Given this list of marker genes BSG (NCBI Gene Id 682), SLC16A7, SLC16A1 (solute carrier family 16 member 1), EMB, SLC16A8, SLC16A3, here is a description of the gene set: Reactome Pathway: Proton-coupled monocarboxylate transport studied in species Homo sapiens part of: SLC-mediated transport of organic anions The SLC16A gene family encode proton-linked monocarboxylate transporters (MCT) which mediate the transport of monocarboxylates such as lactate and pyruvate. Monocarboxylates are a major energy source for all cells in the body so their transport in and out of cells is crucial for cellular function. To date, 14 SLC16A members have been identified through sequence homology. Of these 14 members, only seven isoforms have been functionally characterized and not all of these function as proton-coupled transporters. A number can transport diuretics, thyroid hormones and aromatic amino acids. The seven remaining SLC16A members are classed as orphan MCTs (Morris & Felmlee 2008, Merezhinskaya & Fishbein 2009).<br><br>In mammalian cells, MCTs (monocarboxylate transporters) require association with an ancillary protein to enable plasma membrane expression of the active transporter. Basigin (BSG, CD147) is the preferred binding partner for MCT1, MCT3 and MCT4, while MCT2 requires Embigin (EMB).